The following is a description of a gene set: Any process in which the vacuole is transported to, and/or maintained in, a specific location within the cell. species: Mus musculus Mouse Gene Set: GOBP_VACUOLAR_LOCALIZATION, and this is the list of marker genes: Fes, Stxbp2, Borcs8, Ptgdr, Cbl, Il4ra, Gab2, Gata2, Adora2b, Cd300a, Fam98a, Snapin, Rab34, Fcer1a, Vps33b, D6Wsu163e, Myh9, Lyn, Kif1b, Unc13d, Mrgprx2, Scn11a, Stxbp1, Syk, Lamtor1, Rab44, Grp, Arl8b, Ptgds, Lat2, Kif5b, Borcs6, Hmox1, Nppa, Flcn, Tac4, Tfeb, Rnf167, Clnk, Snx4, Cplx2 (NCBI Gene Id 12890), Mrgprb1, Plekhm1, Il13ra2, Hdac6, Btk, Gata1, Ighe, Borcs5, Rasgrp1, Pip4p1, Map6, Ndel1, Hps6, Nr4a3, Adora3, Slc18a2, Crhr1, Snap23 (NCBI Gene Id 98773), Pld2, Sphk2, Milr1, Kxd1, Vps33a, Fgr, Foxf1, Fcer1g, Rab3a, Pdpk1, Cd84, Plekhm2, Klc2, Bloc1s1, Nppc, Rabgef1, Rac2, Gpr15lg, Borcs7, Ywhaz, Ms4a2, Tmem106b, Il4, Sytl4, Pla2g3, Bloc1s2, Chga, Kit, Vamp8, Def8, Spag9, Il13, Lat